The following is a description of a gene set: Genes in the cancer module 194. Human Gene Set: MODULE_194 studied in species Homo sapiens, and this is the list of marker genes: ALDH9A1, ALDH1A3, ALDH4A1, ALDH3B1, ALDH3A1, ALDH1A2, ALDH6A1, ALDH3A2, ALDH3B2, GAPDHS, ALDH5A1, AOX1, ALDH7A1, ALDH1A1, BCKDHA